Given this list of marker genes GJA8, GJB4, TUBA8, TUBB4A, TUBB4B, GJA3, TUBB2A, TUBA3D, GJA10 (gap junction protein alpha 10), GJB1, GJB3, TUBA1B, GJC2, TUBA4B, TUBB1, TUBA3E, GJD4, TUBA1C, TUBB8, TUBB3 (NCBI Gene Id 94749), GJB6, TUBA1A (NCBI Gene Id 95407), TUBA3C, GJB7, TUBB6, GJD2, TUBB2B, GJC1, GJA5, TUBB8B, GJB2, TUBAL3, GJD3, GJA9, GJA4, TUBA4A, GJB5, GJA1, here is a description of the gene set: Reactome Pathway: Gap junction assembly part of: Gap junction trafficking The assembly of gap junctions involves (1) synthesis of connexin polypeptides at endoplasmic reticulum membranes, (2) oligomerization into homomeric- and heteromeric gap junction connexons (hemi-channels), (3) passage through the Golgi stacks, (4) intracellular storage within Trans Golgi membranes, (5) trafficking along microtubules, (6) insertion of connexons into the plasma membrane, (7) lateral diffusion of connexons in the plasma membrane, (8) aggregation of individual gap junction channels into plaques, and (9) stabilization of peripheral microtubule plus-ends by binding to Cx43-based gap junctions (see Segretain and Falk, 2004.) studied in species Homo sapiens